The following is a description of a gene set: species: Mus musculus Any process that results in a change in state or activity of a cell (in terms of movement, secretion, enzyme production, gene expression, etc.) as a result of a ionizing radiation stimulus. Ionizing radiation is radiation with sufficient energy to remove electrons from atoms and may arise from spontaneous decay of unstable isotopes, resulting in alpha and beta particles and gamma rays. Ionizing radiation also includes X-rays. Mouse Gene Set: GOBP_CELLULAR_RESPONSE_TO_IONIZING_RADIATION, and this is the list of marker genes: Ccnd2, Brcc3, Ifi213, Rhob, Grb2, Rad9b, Itgb6, Hus1, Xrcc6, Ifi207, Tlk2, Swi5, Rad9a, Babam2, Egr1, Ino80, Brcc3dc, Ifi203, Net1, Zmpste24, Ifi208, Rad51, Gadd45a, Rad1, Sfrp1, Ifi209, Lig4, Sfrp2, Mdm2, Atr, Elk1, Fbxo4, Chek2, Nucks1, Tspyl5, Map3k20, Ifi214, Ddias (DNA damage-induced apoptosis suppressor), Prap1, Hras, Tank, Trp53bp1, Trp53, Tnf, Sirt1, Eef1d, Kdm1a, Ints7, Ifi203-ps, Spidr, Cdkn1a, Tgfb1, Rad51ap1, Atm, Tnks1bp1, Tmem109, H2aj, Rhno1, Ect2, Mndal, Clock, Blm, Cdkn2a, Cryab, H2ax, Kdm4d, Bard1, Yap1, Fignl1, Brca1, Mapk14, Brca2, Wrn (Werner syndrome RecQ like helicase), Gata3, Rnf4, Snai2, Gtf2h5, Hsf1, Nipbl, Rpl26, Bcl2l1, Xrcc5, Ifi206, Bbc3, Trex1